The following is a description of a gene set: studied in species Homo sapiens from publication Daryadel A, Yousefi S, Troi D, Schmid I, Schmidt-Mende J, Mordasini C, Dahinden CA, Ziemiecki A, Simon HU (PMID 19414807) The objective of this study was to compare the transcriptional repertoire of mature human neutrophils before and after GM-CSF treatment by using oligonucleotide microarrays. Leukotriene B4 (LTB4) is an important pro-inflammatory lipid mediator generated by neutrophils upon activation. Granulocyte/macrophage colony-stimulating factor (GM-CSF) stimulation is known to enhance agonist-mediated LTB4 production of neutrophils within minutes, a process called “priming”. Here, we demonstrate that GM-CSF also limits the production of LTB4 by neutrophils via a transcriptional mechanism at later time points. We identified hematopoietic specific Ras homologous (RhoH)/translocation three four (TTF), which was induced following GM-CSF stimulation in neutrophils, as a key regulator in this process. Neutrophils derived from RhoH/TTF-deficient (Rhoh-/-) mice demonstrated increased LTB4 production upon activation compared with normal mouse neutrophils. Moreover, neutrophils from cystic fibrosis patients expressed enhanced levels of RhoH/TTF and generated less LTB4 upon activation compared with normal human neutrophils. Taken together, these data suggest that RhoH/TTF represents an inducible feedback inhibitor in neutrophils that is involved in the limitation of innate immune responses. Genes down-regulated in neutrophils treated with CSF2 versus control. Human Gene Set: GSE15139_GMCSF_TREATED_VS_UNTREATED_NEUTROPHILS_DN, and this is the list of marker genes: APC, UPF2, DAPP1, LIME1, RNPC3, RGP1, ARV1, RALGAPA1, RAB14, SLC45A4 (NCBI Gene Id 57210), SELP, RCBTB1, MAP3K21, SULF2, MYO5A, FANCD2, CNRIP1, TRAK1, TDRKH, RCN2, PWWP2B, HNRNPA0 (NCBI Gene Id 10949), CSGALNACT1, ZMIZ2, DNAJC2, GET1, GNB1L, FAM91A1, EIF4G3, CPSF3, TRIM25, SLC25A2, CCDC6, PLK1, OTUB2, SCOC, FBXO31, APRT, FTSJ3, BRCA2, AGPAT4, OAS1, NSUN2 (NOP2/Sun RNA methyltransferase 2), MDC1, SET, CWC27, NOL8, IPMK, CENPU, ALDH18A1, PDLIM1, DCUN1D2, CCDC9, NRF1, TAMALIN, SRP72, ZFP90, GPRASP3, RUNX3, CENPM, PYCR1, NCOA2 (nuclear receptor coactivator 2), G3BP1, C10orf88, ZMYM4, ZCCHC4, TMEM238, PCNT, SACS, PPM1F, EED, CALCRL, GAA, POP1, PDE4DIP, WDR31, PPM1G, TMEM165, POLR2F, ERAP1, XPOT, PDCD7, SATB1, NRAS, AEBP2, SMC5, NIBAN1, TTI2, SPRN, OTUD6B, PA2G4 (NCBI Gene Id 5036), ACTR2, MRPL35, UVSSA, RBM15B, FAM120B, SRSF10, C19orf48P, KCTD13, ARHGAP21, AVEN, KDM5A, PSD2, EPS15L1, NFKB1, PRKCQ (NCBI Gene Id 5588), INTS8, ARL4D, INO80E, GNPDA1, CAAP1 (NCBI Gene Id 79886), KNTC1, SRSF1, ATP2B2, PRKCH, SCO1, SEC63, KIFAP3, APOLD1, RPRD2 (regulation of nuclear pre-mRNA domain containing 2), RUVBL1, DHX29, PORCN, DHRS3, GPAM (glycerol-3-phosphate acyltransferase, mitochondrial), FLT1, MKRN2, ELP5, DUSP14, TRIM5, TMEM87A, FAM204A, SMG1, CCNF, CS, SNX11, VAC14, NFE2L2, CPM, SLC7A1 (NCBI Gene Id 6541), LMAN2L, SRBD1, POLE, CDK6, KLF10, TMEM214, SDHA, PTCH1, CRIP2, TNFRSF10A, OMA1, CPOX, DNAJC21, DCAKD, KLF6 (NCBI Gene Id 8025), FUS, ESYT1, ADAR, FZR1, USP14, STAT5A, DHX58, RBMXL1 (NCBI Gene Id 494115), ELAC2, TXNRD2, CLASRP, DNAJB11, PHTF2, MRTFB, SEC11A, CTNNA1, CHID1, LATS1, SERPINC1, SLC66A3, LARP4B, HBP1, CHML, CARS1, YWHAB, LARP1, ZWILCH, CCDC82, DNAJA4, LAS1L, CHST15, PTPRC, GEMIN5, CRELD2, ATG3, TBRG4, TRAM2, DDX6, DHX33, TMEM181, FPGT, CDON, MAN2A1, RFWD3